Given this list of marker genes SNORA74A, NHP2, RPP38, DKC1, TERC, RPP25, SNORA62, POP1, NAF1, FBL, GAR1, RPP40, NOP10, MPHOSPH10, RRP9, FBLL1, LSM6 (LSM6 homolog, U6 small nuclear RNA and mRNA degradation associated), SNRNP40, POP4, SNORA63, NOP58 (NOP58 ribonucleoprotein), POP5, POP7, SNU13, RPP30, SNORA73A, NOP56, RPP25L, here is a description of the gene set: species: Homo sapiens Human Gene Set: GOCC_SNO_S_RNA_CONTAINING_RIBONUCLEOPROTEIN_COMPLEX A ribonucleoprotein complex that contains an RNA molecule of the snoRNA family and associated proteins. Many are involved in a step of processing of rRNA molecules: cleavage, 2'-O-methylation, or pseudouridylation, but other RNA types can be targets as well. The majority fall into one of two classes, box C/D type or box H/ACA type, which are conserved across eukaryotes and archaea. Other members include the telomerase RNA and the ribonuclease MRP RNA.